Given this list of marker genes FANCE, FANCM, FANCD2, FANCF, FANCA, BRIP1, FANCB, FANCG, BRCA2, FANCC, FANCL, here is a description of the gene set: Fanconi anaemia (FA) is a rare recessive disorder associated with chromosomal fragility, aplastic anaemia, congenital abnormalities and a high risk of cancer, including acute myeloid leukaemia and squamous cell carcinomas. The identification of 11 different FA genes has revealed a complex web of interacting proteins that are involved in the recognition or repair of DNA interstrand crosslinks and perhaps other forms of DNA damage. Bi-allelic mutations in BRCA2 are associated with a rare and highly cancer-prone form of FA, and the DNA helicase BRIP1 (formerly BACH1) is mutated in FA group J. There is little convincing evidence that FA heterozygotes are at increased risk of cancer, but larger studies are needed to address the possibility of modest risk effects. Somatic inactivation of the FA pathway by mutation or epigenetic silencing has been observed in several different types of sporadic cancer, and this may have important implications for targeted chemotherapy. Inhibition of this pathway represents a possible route to sensitization of tumours to DNA crosslinking drugs such as cisplatin. from publication Mathew CG (PMID 16998502) species: Homo sapiens Genes identified with the Fanconi anemia (FA) and the FA pathway. Human Gene Set: MATHEW_FANCONI_ANEMIA_GENES